Given this list of marker genes Mmp28, Edn2, Akirin1, Slamf1, P2rx4, Cd200, Ptk2, Il34, Hc, Ror2, Ccl2, Enpp1, Mmp2, Csf1, Stap1, Cx3cr1, Mtus1, Nup85, C5ar1, Ccr2, Abr, Emilin1 (elastin microfibril interfacer 1), Bcr, Mst1, Cd81, Mmp9, Ninj1, Mapk3, Tnfsf18, Ccl21a, Cmklr1, Trem2, Ednrb (endothelin receptor type B), Cd9, Cx3cl1, Gpr35, Trim55, Trem1, Ccr7, Cklf, Mstn, C3ar1, Ccl5, Rtn4, P2ry12, Slamf8, Cyp19a1, Cd200r1, Lgals3, Ptk2b, Mif, Rpl13a, Ccl12, Rarres2, Tafa4, Mmp14, Thbs1, Ptprj, Cxcl17, B4galt1, Cnn2, Mapk1, Csf1r (colony stimulating factor 1 receptor), Mdk, Trpv4, Mcoln2, Myo9b, Ccl3, here is a description of the gene set: Mouse Gene Set: GOBP_MACROPHAGE_MIGRATION species: Mus musculus The orderly movement of a macrophage from one site to another.